Given this list of marker genes EGFR, KRT13, REG1A, SLC2A2, ACADSB, GPR37, IL1RAP, NR1H3, CYP7A1, OAT, OTC, PPP1R3C, SLC37A4, MBL2, ABAT, DPP4, BAAT, G6PC1, HPD, ETNK2, SLC1A2, CTRC, PNLIPRP1, HSD11B1, PIPOX, CMAHP, TNNT3, EFNA4, MCM10, TNNC2, SLC17A3, AKR1C1, TNFRSF10B, KRT4, SELENBP1, LECT2, C4BPA, BHMT, CYP7B1, MCM7, HAL, NETO2, RNASE4, ELANE (NCBI Gene Id 6417), CA3, HBP1, SULT1B1, TRPV2, TNNI2, PRODH, PNLIP, CYP2E1, PCK1, GSTA4, CA5A, CYP26A1, CYP2F1, KYNU, MAPKAPK2, HSD3B2, PAH, BCL6, WNT10B, DMBT1, PON1, SERPINA6, here is a description of the gene set: Human Gene Set: LEE_LIVER_CANCER_CIPROFIBRATE_DN Genes down-regulated in hepatocellular carcinoma (HCC) induced by ciprofibrate. from publication Lee JS, Chu IS, Mikaelyan A, Calvisi DF, Heo J, Reddy JK, Thorgeirsson SS (PMID 15565109) species: Homo sapiens Genetically modified mice have been extensively used for analyzing the molecular events that occur during tumor development. In many, if not all, cases, however, it is uncertain to what extent the mouse models reproduce features observed in the corresponding human conditions. This is due largely to lack of precise methods for direct and comprehensive comparison at the molecular level of the mouse and human tumors. Here we use global gene expression patterns of 68 hepatocellular carcinomas (HCCs) from seven different mouse models and 91 human HCCs from predefined subclasses to obtain direct comparison of the molecular features of mouse and human HCCs. Gene expression patterns in HCCs from Myc, E2f1 and Myc E2f1 transgenic mice were most similar to those of the better survival group of human HCCs, whereas the expression patterns in HCCs from Myc Tgfa transgenic mice and in diethylnitrosamine-induced mouse HCCs were most similar to those of the poorer survival group of human HCCs. Gene expression patterns in HCCs from Acox1(-/-) mice and in ciprofibrate-induced HCCs were least similar to those observed in human HCCs. We conclude that our approach can effectively identify appropriate mouse models to study human cancers.